Given this list of marker genes Gm14391, Zfp965 (NCBI Gene Id 100503949), Vdac3, Cnn1, Gm4724, Mef2a, Nit1, Gm14308, Gm2026, Zfp970, Strbp, Rora, Spin1, Gm14434, Acat3, Zfp967, Samd8, Zfp966 (NCBI Gene Id 667962), Zfp1008, Sec14l4 (NCBI Gene Id 216512), Zfp1009, Lrrc34, Cd4, Shank2, Gm14325, Zfp936, Gm14296, Gm6710, Trim60, Zfp935, Zfp973, 2210418O10Rik, here is a description of the gene set: studied in species Mus musculus Mouse Gene Set: MIR_7228_3P from publication Chen Y, Wang X (PMID 31504780) Genes predicted to be targets of miRBase v22 microRNA mmu_miR_7228_3p in miRDB v6.0 with MirTarget v4 prediction scores > 80 (high confidence targets).